Given this list of marker genes Cnn2, H2-Eb1, H2-Aa, Rnh1, Ifitm2, Ptpn1, Nenf, Wipf1, Clta, here is a description of the gene set: Mouse Gene Set: CUI_MIGDC_IL27_RESPONSE_UP studied in species Mus musculus Genes positively differentially expressed in cell type: MigDC (migratory dendritic cell) upon treatment with cytokine: IL-27 in mouse lymph nodes in vivo. Cytokines mediate cell-cell communication in the immune system and represent important therapeutic targets. A myriad of studies have highlighted their central role in immune function, yet we lack a global view of the cellular responses of each immune cell type to each cytokine. To address this gap, the authors created the Immune Dictionary, a compendium of single-cell transcriptomic profiles of more than 17 immune cell types in response to each of 86 cytokines (>1,400 cytokine-cell type combinations) in mouse lymph nodes in vivo. A cytokine-centric view of the dictionary revealed that most cytokines induce highly cell-type-specific responses. For example, the inflammatory cytokine interleukin-1β induces distinct gene programmes in almost every cell type. A cell-type-centric view of the dictionary identified more than 66 cytokine-driven cellular polarization states across immune cell types, including previously uncharacterized states such as an interleukin-18-induced polyfunctional natural killer cell state. from publication Cui A, Huang T, Li S, Ma A, Pérez JL, Sander C, Keskin DB, Wu CJ, Fraenkel E, Hacohen N (PMID 38057668)